Given this list of marker genes TLE3, CRAMP1, ITGA8, NCAN, PI4K2A, RASL10B, NCK1, PALD1, ZNF646, PALM2AKAP2, PDE1C, CHST2, RFX5, FUT1, FRMD5, ZNF512B, FGF7, TSPYL1, FOXK1, FMO5, ZNF618, RAB37, CCR2, MAPK8IP3, AGO4, ASPH, GTPBP1 (NCBI Gene Id 9567), E2F2, TLCD4-RWDD3 (TLCD4-RWDD3 readthrough), USP53, SOX11, KIDINS220, SPATA31D3, SMAD9, SPATA13, DTX4, LBH, CMTM3, PYCR1, CNNM4, PPP1R37, SPATA31D4, EVX1, MMP26, ASIC1, E2F3, TANC2, SLC10A6 (solute carrier family 10 member 6), BARX2, KMT5C, TRIQK, TMEM239, MAP2K4, RAP2A, DUSP6, OLAH (NCBI Gene Id 55301), NKD1, TACC2, TNRC6B, PHETA1, EDEM1 (NCBI Gene Id 9695), RPGRIP1L, ARSI, DPH2, EDN1, DYNLL2, GNAI2, ATG14, ELFN2, NEDD9, CD44, MAP1A, ANKRD13B, TOB2, BICRAL, KCNQ3, BCL2L11, ATXN1L, EBF4, KCNC2, CAPN15, IGSF11, TMEM116, USP38, IST1, MBD1, MICALL1, TAS2R14, BTN3A1, SPEG, AGAP1, here is a description of the gene set: Human Gene Set: MIR7113_3P from publication Chen Y, Wang X (PMID 31504780) Genes predicted to be targets of miRBase v22 microRNA hsa-miR-7113-3p in miRDB v6.0 with MirTarget v4 prediction scores > 80 (high confidence targets). studied in species Homo sapiens